Given this list of marker genes ITGAV, YES1, PLCG1, PECAM1, SRC, LYN, ITGB3, FYN, PTPN11, LCK, PTPN6, INPP5D, here is a description of the gene set: Human Gene Set: REACTOME_PECAM1_INTERACTIONS studied in species Homo sapiens PECAM1 interactions